Given this list of marker genes TDG, UCKL1, UPRT, STPG4, AICDA (activation induced cytidine deaminase), TYMS, CTPS2, NME2P1, OGG1, CRMP1, SLC19A3, MBD4, THTPA, NTHL1, NME1, DCTD, DPYSL4, UCK1, DUT, SLC25A19, CDA, NME3, UPP1, SMUG1, UNG (NCBI Gene Id 7374), DHODH, DCK, ACP3, TYMP, SHMT1, UPP2, ENTPD7, APOBEC3C, MAPK1, NEIL1, SLC4A7, ENPP3 (NCBI Gene Id 5169), CMPK2, TKTL1, AK5, ERH, DCTPP1, NME5, SLC19A2, NME7, DPYSL5, ENTPD4, NME9, MTOR, NME2, CMPK1, TPK1, CAD, DTYMK, TK1, APOBEC3G, DPYSL2, CPS1, DHFR2, DPYSL3, CTPS1, ALDH6A1, AK9, RRM1, AK3, DPYS, CDADC1, NT5C, NEIL2, TBPL1, TK2, UCK2, UMPS, ENTPD5, DPYD, NME6, NT5M, NT5C3A, PRPS1, NME4, UPB1, here is a description of the gene set: The chemical reactions and pathways involving a pyrimidine-containing compound, i.e. any compound that contains pyrimidine or a formal derivative thereof. species: Homo sapiens Human Gene Set: GOBP_PYRIMIDINE_CONTAINING_COMPOUND_METABOLIC_PROCESS